Given this list of marker genes CYBA, RETREG1, MPV17, PLEKHM1, NCF2 (NCBI Gene Id 4688), CLCN7, NTRK1, ATL1 (atlastin GTPase 1), FLVCR1, CLTCL1, ATL3, EFL1, HPGD, ANO5, DOCK8, PGM3, SPTBN1, NGF, CD79B, HLA-B, ITGB2, RAB7A, DNAJC21, TCF3, LPIN2, SCNN1A, LRRC8A, IL12RB1, IFNGR1, CD79A, C2orf69, HBB, ZNF341, IGLL1, DNMT1, SBDS, MCTS1, NCF1, TBK1, SPTLC2, PIGH, FOXP3 (NCBI Gene Id 50943), SLC39A7, REL, GATA2, MTAP, SLCO2A1, SCNN1G, SCNN1B, BTK, SPTLC1, TNFSF11, SYK, EN1, BLNK, ATP7A, CYBB, CCT5, TCIRG1, IL1R1, RFX5, PIK3R1, SPI1, STAT1, IGHM, IL1RN, IKBKG, STAT3, here is a description of the gene set: Human Gene Set: HP_OSTEOMYELITIS Osteomyelitis is an inflammatory process accompanied by bone destruction and caused by an infecting microorganism. studied in species Homo sapiens Osteomyelitis